Given this list of marker genes USP20, EPHB2, DRC3, CASP10, WBP4 (WW domain binding protein 4), NOS2, ZNF133, TANC2, DPT, EXTL3, HABP4, NRTN, FNTB, CTRL, COQ7, TBC1D22A, TMEM184B, PIGF, MSH3, CAMK2G (calcium/calmodulin dependent protein kinase II gamma), CHD9, EP400, FRYL, KRT86, PGM3, ZNF500, PHLDB1, KLRC4, FUT6 (fucosyltransferase 6), PRIM2, KIAA0586, FPR2, POU6F1, FOSL1, PPP1R12B, CPZ, C1orf216, NR2C1, SULT2B1, TFDP2, POP4, GPATCH8, LTBP4, AQP5, LY9, SULT4A1, ERCC4, SCAMP1, CDYL, NFX1, BMP10, GPR15, MC5R, HNF1A, TAF2, TMEM11, PSG1, CPEB3, CNKSR1, PAXIP1, NF1, GRIK5, DNAJC16, CEP162, ABCB9, AFF2, FGF18, POLA1, ATP8B1, FRY, RREB1, AMFR, OR2B6, TSSK2, ATRX, SIM2, CYP2D6, MON2, COL19A1, HSPA13, CPSF4, ESR1, HOXD4, KHK, ZBTB22, PSMF1, CFH, RXRG, DMPK, ATF2, PIAS2, ADCY3, ZNF592, COLQ, SYNJ2, DKK4 (dickkopf WNT signaling pathway inhibitor 4), KLHL18, AMMECR1, PRKACA, SURF2, AOC4P, CRHR1, TTLL5, HIC2, DIMT1, RNF14, COX6A2, MSL3, SLC22A6, ELAVL2, SLC16A5, GPR19, NKRF, PITPNA, POFUT2, RUNX2, SUPT3H, CLOCK, KRT2, NTNG2, SLC17A3, PAX9 (paired box 9), PHF10, UBE4B, ATP6V1B1, PIK3CB, SLC4A3, BPHL, REV3L, HCRT, KRT33A, SMG1, CPB2, GJB5, ZNF266 (NCBI Gene Id 10781), SLC18A1, GLE1, ERC1, PPP1R3D, RUNX1, ZNF157, PLEKHB1, ZBTB14, PPP2R5B, PTEN, NRP2, ABO, JADE3, SPA17, PVR, BRCA1, MDM2, NPFF, BNIP1, SERPINA4, GNA11, NFYB (nuclear transcription factor Y subunit beta), PAX7, HTR7, NXPE3, ZSCAN26, JRK, ARL3, PCF11, ARHGAP12, TNIK, BARX2, HTR1E, FOXD1, POLR2K, GNPAT, MFN1, LPGAT1, SMYD5, RAP1A, RAD51D, CACNB1, KRR1, TTI1, SLC2A1, IL16, SPRED2, PPP5C, ZNF134, AMOT, TRIM24, NFAT5, SYT5, SLC33A1, DGCR5, CYP2E1, POU6F2, GRIP2, NMT1, ABCC8, KAZN, FIG4, GPR18, IKBKE, TAF5L, ATP6V0A2 (NCBI Gene Id 7854), CYP11A1, ABCB10, USP46, LEPROTL1, MAGEA9, CDC73, ATXN3, IGKV7-3, ITIH3, INPP5E, GNG4 (G protein subunit gamma 4, NCBI Gene Id 2786), TBX19, IFT27, PIK3C2A, COLGALT2, PDE6A, FSHR, ZNF33B (zinc finger protein 33B), SPAST, P2RY10, CLPX, WIPF2, RPS6KA5, IL13, BRWD1, CAMK4, PRELID3A, ZBTB40, OPLAH (5-oxoprolinase, ATP-hydrolysing), YAF2, CCNF, KLHDC10, MLLT10, NR1I2, IQCK, CELA2B, AQP7, DOCK1, IRF2, HOXA11, PPP1R1A, GTSE1, here is a description of the gene set: Neighborhood of MSH3 Neighborhood of MSH3 mutS homolog 3 (E. coli) in the MORF expression compendium Human Gene Set: MORF_MSH3 species: Homo sapiens